Given this list of marker genes ATP1A4, BMPR1B-DT, MSTN, LINC02355, GJB2, CLU, ENSG00000273360, LINC00402, DNAH7, COL22A1, HHIP, ID4, LIPG, OBI1-AS1, ENSG00000188897, CFAP107 (cilia and flagella associated protein 107, NCBI Gene Id 93190), PRDM16, CFAP300, CA12, CD38, RNY1P5, BTBD17, GBX2-AS1, THBS3-AS1, GLP1R, ABCA8, FAM216B, MLIP, NTS, LINC00939, SIPA1L1-AS1, ACADL, CFAP52, ENSG00000200072, LINC02078, DAZL, ALDH1L1-AS2, LINC03109, LGR6, OR51E2, MLC1, LINC02552, FST, FGF10, SIRPB3P, WNT9B, MGST1, SLITRK6, FOXJ1, FHIP1A, LINC00856, EGFR, CYP26A1, AGTR1, CRB2, NPY, FOXB1, AQP4, WARS2-IT1, ACTE1P, SERPINI2, MS4A8, LRTM1, ARMC3, CKAP2LP1, PTGFR, IRX3, COL2A1, OPRK1, LINC01198, LCAT, PAX3, NRXN1-DT, LRRC10B, FAM181A-AS1, ENKUR, CYP4F35P, IQCA1-AS1, ENSG00000232930, NALCN-AS1, RPL31P54, RNGTTP1, TEKT1, VCAM1, SLC6A20, LINC01994, BLID, CTNNA3, USH1C, NPHP1, ENSG00000247193, CFAP210, LINC00446, TNC, DTHD1, OTOG, FRMPD2, ZNF863P, LRRC9, CFAP73, CYP26B1, ENSG00000259403, IL5RA, ALDH1L1, LINC02925, MAP3K19, SOHLH2, WDR49, PPP1R42, CCDC140, MEGF10, MKX, CFAP54, ACSBG1, PRSS35, MTTP, CABCOCO1, DAW1, SNX31, RNU6-1331P, RASGRP1, RPE65, CCDC169, NCKAP5-IT1, KCNMA1-AS1, LNCBRM, IRX5, CCDC198, RGS20, LINC02017, GDPD2, LRP4, LRIG1, CYP26C1, RAMP3, MARVELD3, TNFRSF11B, IL33, ENSG00000262999, PIK3C2G, GLI1, PI15, GBX2, BBOX1, FREM1, PAX7, KIRREL2, PIRT, STK33, CASQ1, GJB6, VWA3A, TMEM221 (transmembrane protein 221), LINC01411, STMND1, TENT5A, RMDN2-AS1, DPPA5P4, NOG, ADAMTS12, SLC4A4, PIRAT1, GFAP, SPATA13, OR51B5, CCDC102B, FAM81B, EFHC2, PTF1A, TSHR, FZD10 (NCBI Gene Id 11211), ADRA1D, here is a description of the gene set: Marker genes curated from the annotated cluster as represented in the Descartes Human Gene Expression During Development database. Human Gene Set: DESCARTES_FETAL_CEREBELLUM_ASTROCYTES from publication Cao J, O'Day DR, Pliner HA, Kingsley PD, Deng M, Daza RM, Zager MA, Aldinger KA, Blecher-Gonen R, Zhang F, Spielmann M, Palis J, Doherty D, Steemers FJ, Glass IA, Trapnell C, Shendure J (PMID 33184181) studied in species Homo sapiens The gene expression program underlying the specification of human cell types is of fundamental interest. The study authors generated human cell atlases of gene expression and chromatin accessibility in fetal tissues. For gene expression, the study authors applied three-level combinatorial indexing to >110 samples representing 15 organs, ultimately profiling ~4 million single cells. The study authors leveraged the literature and other atlases to identify and annotate hundreds of cell types and subtypes, both within and across tissues. Our analyses focused on organ-specific specializations of broadly distributed cell types (such as blood, endothelial, and epithelial), sites of fetal erythropoiesis (which notably included the adrenal gland), and integration with mouse developmental atlases (such as conserved specification of blood cells). These data represent a rich resource for the exploration of in vivo human gene expression in diverse tissues and cell types.